The following is a description of a gene set: Marker genes curated from the annotated cluster as represented in the Descartes Human Gene Expression During Development database. The gene expression program underlying the specification of human cell types is of fundamental interest. The study authors generated human cell atlases of gene expression and chromatin accessibility in fetal tissues. For gene expression, the study authors applied three-level combinatorial indexing to >110 samples representing 15 organs, ultimately profiling ~4 million single cells. The study authors leveraged the literature and other atlases to identify and annotate hundreds of cell types and subtypes, both within and across tissues. Our analyses focused on organ-specific specializations of broadly distributed cell types (such as blood, endothelial, and epithelial), sites of fetal erythropoiesis (which notably included the adrenal gland), and integration with mouse developmental atlases (such as conserved specification of blood cells). These data represent a rich resource for the exploration of in vivo human gene expression in diverse tissues and cell types. studied in species Homo sapiens Human Gene Set: DESCARTES_FETAL_HEART_SCHWANN_CELLS from publication Cao J, O'Day DR, Pliner HA, Kingsley PD, Deng M, Daza RM, Zager MA, Aldinger KA, Blecher-Gonen R, Zhang F, Spielmann M, Palis J, Doherty D, Steemers FJ, Glass IA, Trapnell C, Shendure J (PMID 33184181), and this is the list of marker genes: RHEBL1, ST6GALNAC2, ATP10B, COL20A1, PLEKHA4, LINC01339, PLXNB3, HSPB2-C11orf52 (HSPB2-C11orf52 readthrough (NMD candidate)), XKR4, TENM3, ARSL, MMD2, CDH19, PMP2, CTXND1, ST3GAL6-AS1 (ST3GAL6 antisense RNA 1), CARMAL, GRAMD2A, LINC00327, LINC01505, LINC00466, MAG, OLFML2A, MEGF10, COL22A1, FOXD3, GFRA3, ZNF536, PLP1, MYOT, ANGPTL7, MIA, ITIH5, RXRG (retinoid X receptor gamma), CHST9, CFAP61, CNMD, MPZ, ARTN, ALDH1A1, LINC02698, NR4A2, ALDH1A3, GINS3, NLGN3, BMP8B, KCNJ10, SLC9A3-OT1, SHC4, COL28A1, ERBB3, TENM3-AS1, METRN, ASPA, TFAP2A (transcription factor AP-2 alpha), CLDN14, LINC01608, MIR663AHG, INSC, LGI4, TSPAN11, GPR17 (G protein-coupled receptor 17), PRIMA1, COL2A1, S100B, LINC01198 (long intergenic non-protein coding RNA 1198), SOX10